Given this list of marker genes Pcif1, Stom, Tcerg1, Ercc6, Ago1 (argonaute RISC catalytic subunit 1), Wdr43, Rprd1b, Uri1, Ccnt2, Uvssa, Dhx9, Cdc73, Ncoa3, Ago2, Scaf1, Maf1, Wdhd1, Wac, Smyd3, Elof1, Erbb2, Scaf8, Myzap, Per2, Ercc5, Rprd2, Elp2, Taf10, Polr2m, Supt4b, Phrf1, Nedd4, Scaf4, Anp32b, Gsg1, Ythdc2, Pabpn1, Esrrb, Rtf1, Rtraf, Rrn3, Pcf11, Paf1, Ppib, Elp4 (NCBI Gene Id 77766), Brca1, Rprd1a, Zfp36, Tcerg1l, Smyd2, Leo1, Hnrnpu, Spty2d1, Ccnt1, Gtf2b, Pkn2, Brd4, Supt4a, Ctr9, Rpap2, Bin1, Recql5, Ccar2, Zfp326, here is a description of the gene set: species: Mus musculus Binding to an RNA polymerase molecule or complex. Mouse Gene Set: GOMF_RNA_POLYMERASE_BINDING